Given this list of marker genes SLC35G1, CD82, NFKBIB, PPP1R3F, DEFB4A, MYL10, NIPSNAP3B, BLOC1S6, TBC1D10B, AFP, CDKL2, SLC22A20P, UBXN2A, EARS2 (NCBI Gene Id 124454), ENAM, NUDT9, FERMT1, GTF2H3, FBXL6, CTSL, MC2R, PNPLA2, PPIL1, SCNN1G, PCDHB6, ADAM5, TAS1R3, E2F6, HCCS, MIR132, HSF5, PPAN, ZPBP2, ERCC6L, ACTN3, WDR74, CTNNBL1, ADPRH, CTU1, GAS1, NUDT16L1, FIBP, SLC39A14, SDHAF3, GPATCH1, RTKN2, MTFR1L, SLC7A11, CORO2B, MYD88, THAP2, XYLT2, WDR45B, DUSP4, SEC61G, KLHDC9, ANAPC2, HOXC13, TSPAN8, TRAPPC5, GMPR, CHRNB4, SHC4, ARV1, SLC22A9, CPLX2, CLCN1, TRIB1, COQ6, EME1, MIR302A, MAGEB18 (MAGE family member B18), NUDT4, GEMIN8, MATN2, TMEM30A, VAMP3, CFAP53, BCS1L, PGLS, WSB1, ABHD10, TBC1D19 (NCBI Gene Id 55296), YTHDF1, RNU12, ACVR1 (activin A receptor type 1), WFS1, FAM76A, KLF8, GRB7, MYO1D, TSC1, ENO2, IL1F10, CALHM6, PLBD2, ZFAND3, TMEM9, GLO1, COASY, CNGA2, SLC1A2, EDF1, KLHL31, CD33, DGCR6, MYL6B, AMD1, SLC6A13, ORMDL1, C4BPA, MRGPRX1, A4GALT, TIMM22, NMNAT1, RPL9, ZFAND2A (zinc finger AN1-type containing 2A), OSGEP, HEMK1, HSPB6, JOSD1, CES3, PKM, TMEM203, FAM124B, METTL4, CD79A, SEMA3A, AP4S1, SLC35A4 (NCBI Gene Id 113829), CCT6B, DPYSL3, ANTXR2, CREM, STARD10, TM6SF2, GSTA4, ABHD13, here is a description of the gene set: species: Homo sapiens IL-10 or IL-6 stimulation of control 129xC57BL/6 murine bone marrow derived macrophages in the presence of LPS. We used microarrays to detail the global programme of gene expression changes in response to IL-6 or IL-10 stimulation in the presence of lipopolysaccharide. BMDMs were isolated from control, IL-6-/-, and IL-10-/- mice on a 129XBL/6 mixed background mice and differentiated in the presence of CSF-1 for 6-7 days. Cells were scraped and plated in 6 well plates at 2x10e6/well. Cells were washed with complete DMEM and rested for 1-2 hr before stimulation with combinations of IL-10 (10 ng/ml), IL-6 (2 ng/ml) or LPS (100 ng/ml) for 45 min or 180 mins. Complete biological replicates were performed. from publication El Kasmi KC, Holst J, Coffre M, Mielke L, de Pauw A, Lhocine N, Smith AM, Rutschman R, Kaushal D, Shen Y, Suda T, Donnelly RP, Myers MG Jr, Alexander W, Vignali DA, Watowich SS, Ernst M, Hilton DJ, Murray PJ (PMID 17114459) Human Gene Set: GSE5589_WT_VS_IL6_KO_LPS_STIM_MACROPHAGE_180MIN_UP Genes up-regulated in bone marrow-derived macrophages at 180 min of stimulation byLPS: wildtype versus IL6 knockout.